The following is a description of a gene set: species: Homo sapiens from publication Chen Y, Wang X (PMID 31504780) Genes predicted to be targets of miRBase v22 microRNA hsa-miR-184 in miRDB v6.0 with MirTarget v4 prediction scores > 80 (high confidence targets). Human Gene Set: MIR184, and this is the list of marker genes: TNPO2, FAM169BP, EPB41L5, CES2, PLPP3, NUS1, SETD9, CAMK2B, GNB1